The following is a description of a gene set: Human Gene Set: HP_APLASIA_INVOLVING_BONES_OF_THE_LOWER_LIMBS species: Homo sapiens Aplasia involving bones of the lower limbs, and this is the list of marker genes: TBX5, CHD7, BMPR1B, KCNN3, VAC14, LONP1, LMNA, DYNC2H1, FIG4, GDF5, EOGT, PITX1, GLI3, ATP7A (NCBI Gene Id 613259), LMBR1